The following is a description of a gene set: studied in species Homo sapiens Human Gene Set: MIR203A_3P from publication Chen Y, Wang X (PMID 31504780) Genes predicted to be targets of miRBase v22 microRNA hsa-miR-203a-3p in miRDB v6.0 with MirTarget v4 prediction scores > 80 (high confidence targets)., and this is the list of marker genes: PAQR3, NFIA, DLX5, HTR2A, ZMIZ1, SLC25A46, KAT6A, DIP2B, MYEF2, IFIT3, AQP4, LSM14A, FGD4, ADK, MICAL2, KRT85, PRICKLE2, INSIG1, FRG2, TXNDC16, PTP4A1, TMEM154, SGIP1, PHIP, CREM (cAMP responsive element modulator), TCF4, MBNL3, FMN1, ZBTB11, HYCC2, IFIT1, ABCE1, NR2C2, BBX, LRPAP1 (LDL receptor related protein associated protein 1), E2F3, AFF4, XRN2, NPY2R, NUFIP2, BANF1, WIPF1, TRIM4, CDH10 (cadherin 10), KATNAL2, PLPP3, GLRB, EEF1E1, RAG1 (recombination activating 1), CCZ1B, UPF2, INPP1, KRT26, MACO1 (NCBI Gene Id 55219), SHISA6, PRKAG2, PRKCI, ZNF197, PHF3, DLG5, PIK3CA, MAPK9, CRLF3, AKAP7, NEDD4L, PAPSS2, C2orf80, IMPG1, ACSL1, ETV1, FAT3, SH2D1B, PKHD1L1, KBTBD8, SERP1, ZNF680, SPARC, CSN2, ZNF608, RRAS2, LIFR, ADAM12, PTPN9 (protein tyrosine phosphatase non-receptor type 9), RNASE4, MORF4L1, MSI2, TMPRSS11D, GPATCH1, TPR, PLD2, MMP16, RASAL2, RAB27B, KIF2A, USP8, MMAA, RIPOR2, HMGA2, LRRTM2, RP2, ELOVL6, NSG1, TMEM69, PRKG1, MPDZ, SOX5, PLD1, ALG5, TRPV3, GABRA1, SEC24A, SRC, CEP43 (NCBI Gene Id 11116), MAP1B, KRT35, ALOX15 (arachidonate 15-lipoxygenase), EIF4E, SLC7A11, RFX7, HSDL2, TAF4B, DNAJC27, MBNL1, MCTS1, GPR18 (NCBI Gene Id 2841), GRHL3, CREBRF, PEX5L, UBE2D3, CSRNP2, COX15, CSGALNACT1, GPR180, IL24, NSD2, ARHGAP42, SLC16A12, SPOPL, BCCIP, GBE1, CAB39, UBR1, ADAMTS6, MAPK8, PURG, CLSTN3, RBM47, DCN, SMC5, AHR, PCDHB7, FAM204A, ID4, PHF12, EDRF1, ACVR2A, PTAR1, ZNF763, TMEM33, TNPO1, EPHA5, CFAP97, GABRA4, ROBO2, KITLG, HOOK3, PDPN, B3GALT2, INTS14 (NCBI Gene Id 81556), YTHDF3, TRDN, YAF2, RERG, GATM, SCGB2A1, SRA1, ELAVL4, ADAMTS17, ANKS1B, PRC1, WDR47, COL21A1, GXYLT1, SGMS2, ADGRG2, PHF6, MCTP1, PPP1R12A, VIRMA, WDFY3, ZNF112, TADA2B, RNF141, COPS7B, DDX6, PRPS2, ZCCHC10, PRKCB, EGR3, SLC12A2, SLC4A4, C11orf91, MED14, MEX3C, LRATD1, ELL2, PCDH19, VSNL1, MORF4L2, SEC62, OXGR1, MECP2, MBNL2, FGG, OLFM3, PTPN3, GFM2, RAB10, DNHD1 (dynein heavy chain domain 1), SENP7, WFDC13, SULT1E1, NFIL3, RADX, ADAMTS5, JMY, PSD3, CDK5RAP2, ZBTB20, SGTB, PDHA1, NOCT, CRACD, ZNF148, SNTB2, ERAP1, ITPR2, THSD7A, NLK, B3GNT5, SCYL2, BCL7A, MBLAC2, VAPA, WDR37, PRSS33, ZNF451, ETS2, MEMO1, SESTD1, MAP3K1, CCNC, ZNF281, NSUN7, SNAI2, GPHN, TLCD4 (TLC domain containing 4), MAP3K2, SLC39A9, STRIP2, NUDT21, TTC39A, CRISP1 (cysteine rich secretory protein 1), EGLN1, COL4A4, HNRNPR, SEMA5A, SELENOT, LIN7A, SPOCK3, FOXK1, ST8SIA3, MINDY2, PTPN4, ARFGEF3, IKZF5, NAA30, DUSP5, PCDHGA11, HERPUD2, MEF2C, CNNM3, CASK, TC2N, PDE4D, TARDBP, TNFSF15, DRD1, DPPA4 (developmental pluripotency associated 4), PDAP1, U2SURP, SCP2, CCZ1, SLC7A14, CADM2, SETD7, MAP3K13, LIN28B, TNN, CIBAR1, CCDC50, CLOCK, RASSF6, GLIS3, RCBTB2, MID1, ANKRD52, HNRNPUL2, KLHL4, ACO2 (aconitase 2), CCR1, EIF5A2, ONECUT2, GUCY1A2, DYNLT1, RELT, SMAD1 (SMAD family member 1), HYAL4 (hyaluronidase 4), C6orf118, TMCC3, RICTOR (RPTOR independent companion of MTOR complex 2), PNPLA4, TMEM178B, DAB2, EPYC, RTKN2, DCP2, PHF21B, PDGFD, DCAF10, DENND6A (NCBI Gene Id 201627), SEMA3A, CTTNBP2NL, DUS1L, ZNF14, GABARAPL1, ATG14, RPS6KA6, NR1D2, KRT1, FER, GALNT13, PHLDA1, FUBP3, NAA25, ARMT1, ANTXR2, RAPGEF1, LRCH2, WFDC5, RPAIN, OSBPL8, GOLGA8A, GSKIP, BBOF1, TFDP2, ZNF652, COL17A1, ATF2, TKTL1, NEMF, HCCS, TEDDM1, DR1, ATP2C1 (ATPase secretory pathway Ca2+ transporting 1), TMEM100, DGKB, PSMD5 (proteasome 26S subunit, non-ATPase 5), OPN3, OPA1, DGKH, LNX2